The following is a description of a gene set: studied in species Homo sapiens BACKGROUND: Dendritic cells (DC) play a central role in primary immune responses and become potent stimulators of the adaptive immune response after undergoing the critical process of maturation. Understanding the dynamics of DC maturation would provide key insights into this important process. Time course microarray experiments can provide unique insights into DC maturation dynamics. Replicate experiments are necessary to address the issues of experimental and biological variability. Statistical methods and averaging are often used to identify significant signals. Here a novel strategy for filtering of replicate time course microarray data, which identifies consistent signals between the replicates, is presented and applied to a DC time course microarray experiment. RESULTS: The temporal dynamics of DC maturation were studied by stimulating DC with poly(I:C) and following gene expression at 5 time points from 1 to 24 hours. The novel filtering strategy uses standard statistical and fold change techniques, along with the consistency of replicate temporal profiles, to identify those differentially expressed genes that were consistent in two biological replicate experiments. To address the issue of cluster reproducibility a consensus clustering method, which identifies clusters of genes whose expression varies consistently between replicates, was also developed and applied. Analysis of the resulting clusters revealed many known and novel characteristics of DC maturation, such as the up-regulation of specific immune response pathways. Intriguingly, more genes were down-regulated than up-regulated. Results identify a more comprehensive program of down-regulation, including many genes involved in protein synthesis, metabolism, and housekeeping needed for maintenance of cellular integrity and metabolism. CONCLUSIONS: The new filtering strategy emphasizes the importance of consistent and reproducible results when analyzing microarray data and utilizes consistency between replicate experiments as a criterion in both feature selection and clustering, without averaging or otherwise combining replicate data. Observation of a significant down-regulation program during DC maturation indicates that DC are preparing for cell death and provides a path to better understand the process. This new filtering strategy can be adapted for use in analyzing other large-scale time course data sets with replicates. Genes down-regulated in bone marrow-derived dendritic cellstreated by poly(IC): 1h versus 12h. from publication Olex AL, Hiltbold EM, Leng X, Fetrow JS (PMID 20682054) Human Gene Set: GSE21033_1H_VS_12H_POLYIC_STIM_DC_DN, and this is the list of marker genes: KCTD4, CDKN2C, PRRC2C, EMB, TCEA1, RAD18, STRIP2, USP25, HNRNPC, ZRANB2, ULK2, MIR30E, R3HDM2, CEP97, PIGL, SLC35A3, BMP2K, TAOK1, RSPH10B2, TNRC6A, MAPKBP1, KDM4C, CSNK1G3, PPP4R3B, SPG11, PTK2, PSPH, RBBP6, LYST, CHUK, PIK3CA, EXOC6, FLVCR2, MARCKS, PPP3CB, ELF1, ATF7IP, NKTR, MED1, KHDRBS1, TRAT1, SNX2, MTX3, BEND5, YTHDF3, PDHA2, YIPF4, PDE4D, NR1I2, MIR208A, AKAP7, FAM161B, CYLD, NT5M, FNBP4, NRAS, SNORA28, ZMYM2, RFX7, CLEC7A, GNPDA2, DNAJB9, DAAM1, PRG4, CUEDC1, CCL7, STAM2, TNRC6B, UBXN8, DNAJB7, KDM5A, DOLK (NCBI Gene Id 22845), SNORD87, WASL, MIR186, ADD3, IRAK4, GPR22, SMYD1, APBB1IP, PNMA3, NOL7, TMOD4, TMEM45A, ZBTB34, PHF3, DROSHA, KRTAP6-2, TAF7, PLAC8L1, MOCS2, TFAM, EPC2 (enhancer of polycomb homolog 2), MATN2, ARHGAP26, ZFYVE26, MIGA1, KLHL7, HFE, CD300LD, ANO10, ANGPT2, SNORA75, CABLES2, AGBL4, TAF1B, GOLIM4, FRS2, EPS15, JAK1, LEKR1, HUWE1, RBM4B, MORF4L1 (NCBI Gene Id 10933), SNORA31, SETD2, RAB11FIP1, SP4, PDPK1, GLRX, PUS7L, BAZ2A, IL2RA, PCDHB18P, MPC2, NFE2L2, ASB7, RNF111, VWA5A, MAP4K4, ZBED3, RAB5A, BTBD7, NKAPD1, ARSA, IMPACT (impact RWD domain protein), WNK1, ASH2L, ODC1, RP1L1, RNASE10